The following is a description of a gene set: Most human lymphomas originate from transformed germinal center (GC) B lymphocytes. While activating mutations and translocations of MYC, BCL2 and BCL6 promote specific GC lymphoma subtypes, other genetic and epigenetic modifications that contribute to malignant progression in the GC remain poorly defined. Recently, aberrant expression of the TCL1 proto-oncogene was identified in major GC lymphoma subtypes. TCL1 transgenic mice offer unique models of both aggressive GC and marginal zone B-cell lymphomas, further supporting a role for TCL1 in B-cell transformation. Here, restriction landmark genomic scanning was employed to discover tumor-associated epigenetic alterations in malignant GC and marginal zone B-cells in TCL1 transgenic mice. Multiple genes were identified that underwent DNA hypermethylation and decreased expression in TCL1 transgenic tumors. Further, we identified a secreted isoform of EPHA7, a member of the Eph family of receptor tyrosine kinases that are able to influence tumor invasiveness, metastasis and neovascularization. EPHA7 was hypermethylated and repressed in both mouse and human GC B-cell non-Hodgkin lymphomas, with the potential to influence tumor progression and spread. These data provide the first set of hypermethylated genes with the potential to complement TCL1-mediated GC B-cell transformation and spread. from publication Dawson DW, Hong JS, Shen RR, French SW, Troke JJ, Wu YZ, Chen SS, Gui D, Regelson M, Marahrens Y, Morse HC 3rd, Said J, Plass C, Teitell MA (PMID 17260020) Human Gene Set: DAWSON_METHYLATED_IN_LYMPHOMA_TCL1 Genes hypermethylated in at least one of the lymphoma tumors of transgenic mice overexpressing TCL1 in germinal center B lymphocytes. species: Mus musculus, and this is the list of marker genes: HOXA2, CLVS2, TNS3, CYRIB, TMEM30B, CCSER1, KLHL29, FIGN, EVX2, FOXD3, NCAM1, HOXD13, ESR1, ZDHHC5, OSBPL6, EPHA7, TMEM229A, FAM184A, PLCB4, TNFAIP2, BHLHE22, SLC24A3, RNF180, EGR2, SOX17, ID4, TBX18, MACROD2, IRX3, OPRD1, FOXG1, ISM1, AJAP1, GAS1, PTPRD, CLEC16A, ADGRL2, SOX1, FOXC1, MEDAG, SPRY2, PRR16, MTCL3, PCDH10, NRSN1, TSHZ3, CDKN2A, MDGA2, AUTS2, CADPS2, STK39 (serine/threonine kinase 39), GOLGA5, PKP4, SAMD5, HMGN1, ZIC3, ARHGEF26, RUNX1T1, SOX3